The following is a description of a gene set: from publication Favila MA, Geraci NS, Zeng E, Harker B, Condon D, Cotton RN, Jayakumar A, Tripathi V, McDowell MA (PMID 24808365) Genes down-regulated in dendritic cells: untreated versus 24h after infection of Leishmania major. Human Gene Set: GSE42088_UNINF_VS_LEISHMANIA_INF_DC_24H_DN studied in species Homo sapiens Leishmania major infected human dendritic cells (DCs) exhibit a marked induction of IL-12 ultimately promoting a robust Th1-mediated response associated with parasite killing and protective immunity. In this study, we utilized Affymetrix Genechips to globally assess the host cell genes and pathways associated with L. major infection during early infection (2, 4, 8, and 24 hrs) in human myeloid-derived DCs. Bioinformatic analyses of the hybridized microarray chips identified genes, represented by 848 unique probe sets, which, when compared to uninfected samples were observed to be significantly differentially expressed by one-way ANOVA. Altogether, the data provide a genome-wide perspective on the transcriptional influences Leishmania species exert within human DCs during early infection, and provides a platform for further investigations toward functionally characterizing candidate genes of importance to the IL-12 based immune response to infections. In the current study, we further investigate the L. major infected DC transcriptional during early time points after infection via microarray analysis., and this is the list of marker genes: TTI2, TXNRD1, GMPPB, HLX, ADRM1, KLHL1, VCP, PITRM1, CLIC4, LIG3, UBFD1, CXCL5, PPP3CC (protein phosphatase 3 catalytic subunit gamma), IL12B, PCID2, EHF, BUB1B, CXCL6 (NCBI Gene Id 6372), ADA (adenosine deaminase), SEC61A1, DNAH17, GLRX3, NFYA, TWSG1, MYO1E, RPAP1, TOMM34, SEC61G, CFLAR, SEMA3C, ATP6V1H, SLC11A2, PGM3, TIMM17A, SERPINE2, CRIM1, NRBP1, SLC27A2, NMB, CSF3, USP12, CSTB (cystatin B), DPH2, KEAP1, GTPBP4, CCL24, PSAT1, DHRS2, EBI3, SNX16, CASP7, PEX10, IL15RA, RRP1 (NCBI Gene Id 8568), TTC4, EEF2KMT, NPTN, FGF2, KDM1A, RTN2, MMP10, CCL27, SPINK1, ELOA, PLAT, TRIM16, LSS, CANT1, TNS3, CDK14, IFRD2, SLAMF7, CLGN, TFG, DESI1, FERMT2, PSMA3, BUD31 (BUD31 homolog), TFPI2, GLA, MICALL1, TMEM132A, NRP2, IL6, TXN, WNT5A, TRIP6, MSC, INHBA, NCDN, BCL2L1, CDK5RAP2, ZNF557, TM9SF1, VASP, GCLM, FLOT1, NME1, PRR16, TNIP2, GRB10, IL19, TRAPPC4, ACOX3, SLC1A3, TP53BP1, GPR137B, DLD, DRAM1, IL36G, DYNLL1, PRSS3, MRTO4, GPR107, METTL1 (NCBI Gene Id 4234), BYSL, SETD4, AKT3, PDE4DIP, GART, PDSS1, MAPK12, EGLN3, ANXA5, PID1, AK4, CXCL1, ANXA2P2, EDN1, PRDX1, TNFRSF9, CLIC2, NDP, EMC6, OPTN, MTHFD2L, NQO1, ZNF629, CTSL, PNO1, JAKMIP2, LRP12, IDO1, GOSR2, ENTPD7, IL2RG, RDX, MYO10, CXCL11, WDR1, ATP2C1, CRABP1, LAPTM4B, ALCAM, CYB5R2, TRPC4AP (NCBI Gene Id 26133), ACSL4, PSMA7, BATF, HPD, CD44, WSB2, TRIM36, MMP14, RPAIN, ASS1, C3, YRDC, MAP3K4, CYP27B1, ANKRD40, NSUN3, GDI1, PAICS, PDXK, TNIP3, PSMB5, RIT1, LYRM1 (NCBI Gene Id 57149, LYR motif containing 1), CD59 (NCBI Gene Id 966), CDC5L, RAB13, NIBAN1, EXOSC4, SMS, PSMA6, HRH1, STAM2, TRIP10, MYH8, C1QTNF1, UPB1, RPS6KA3, FSCN1, NOP16, SEPTIN10, MREG, ORMDL2, ZSWIM1